The following is a description of a gene set: species: Mus musculus The end of a filopodium distal to the body of the cell. Mouse Gene Set: GOCC_FILOPODIUM_TIP, and this is the list of marker genes: Ephb1, Nlgn1, Osbpl3, Vil1, Abi2, Abitram, Ube2k, Myo9b, Myo3a, Myo3b, Ttyh1, Myo10 (myosin X), Ap2a1 (NCBI Gene Id 11771), Fmr1, Abi1, Morn4, Cyfip1 (NCBI Gene Id 29878), Fzd3, Myo5a, Cib1